Given this list of marker genes GYG1, EPM2A, GYS2, PPP1R3C, NHLRC1, UBB, SLC37A4, G6PC1, GBE1, GYG2, UBA52, GAA, G6PC3, GYS1, UBC, RPS27A, here is a description of the gene set: studied in species Homo sapiens Glycogen storage diseases Human Gene Set: REACTOME_GLYCOGEN_STORAGE_DISEASES